The following is a description of a gene set: species: Homo sapiens Bursts of large-amplitude multidirectional saccades without intersaccadic interval Human Gene Set: HP_OPSOCLONUS Opsoclonus, and this is the list of marker genes: CLCN7, LIN28B, TCIRG1, MYCN, FRMD5, HACE1, PHOX2B, TMEM240 (NCBI Gene Id 647400), SNX10, KIF1B, LMO1, GBA1, ALK, TNFSF11